The following is a description of a gene set: Mouse Gene Set: CUI_CDC2_IL15_RESPONSE_DN from publication Cui A, Huang T, Li S, Ma A, Pérez JL, Sander C, Keskin DB, Wu CJ, Fraenkel E, Hacohen N (PMID 38057668) Cytokines mediate cell-cell communication in the immune system and represent important therapeutic targets. A myriad of studies have highlighted their central role in immune function, yet we lack a global view of the cellular responses of each immune cell type to each cytokine. To address this gap, the authors created the Immune Dictionary, a compendium of single-cell transcriptomic profiles of more than 17 immune cell types in response to each of 86 cytokines (>1,400 cytokine-cell type combinations) in mouse lymph nodes in vivo. A cytokine-centric view of the dictionary revealed that most cytokines induce highly cell-type-specific responses. For example, the inflammatory cytokine interleukin-1β induces distinct gene programmes in almost every cell type. A cell-type-centric view of the dictionary identified more than 66 cytokine-driven cellular polarization states across immune cell types, including previously uncharacterized states such as an interleukin-18-induced polyfunctional natural killer cell state. Genes negatively differentially expressed in cell type: cDC2 (conventional dendritic cell type 2) upon treatment with cytokine: IL-15 in mouse lymph nodes in vivo. species: Mus musculus, and this is the list of marker genes: Cd79b, Slc38a1, Ssh2, Zfp36l2, Eif4ebp2, Dock11, Plekhm3, Eif3f, Stk10, Trmt112, Eif3e (eukaryotic translation initiation factor 3, subunit E), Ucp2, Klhl24 (NCBI Gene Id 98030), Smc6 (NCBI Gene Id 67241), Shtn1, Apbb1ip, Asap1, Mcemp1, Zfp36l1, Npm1, Rack1, Eif4b, Ccdc88a, Eif4a2, Sptssa, Glud1, Traf3ip3, Ypel3 (yippee like 3), Hps3, Trim7, Ctdsp2, Cep250, Brd3, Btg2, Cbl, Zeb2, Ssbp3 (NCBI Gene Id 72475), Ifngr1, Hnrnpa1, Mxd4, Klf2, Hpgd, Kdm7a, Fmnl1, Pip4k2a, Gdi2, Cdkn1b, Rnf150, Pdlim2, Hes6 (NCBI Gene Id 98321), Ncf2, Ldb1, Nr4a1, Parp1, Skint3, Septin6, Slc12a6, Tubb5, Celf2, Mbnl1, Tsc22d4, Alox5ap (arachidonate 5-lipoxygenase activating protein), Cd300c2, Fos, Prcp, Tbl1xr1 (NCBI Gene Id 99912), Slc66a2, Paip2, Gm2a, Irag2, Mapre2, Ptpn18, Trappc5, Erp29, Emb, Nfam1, Ccl6, Susd3, Kxd1, Bmyc, Ivns1abp, Flt3, Lztfl1, Selenoh, Il16, Borcs6, Elovl5, Naca, Stk17b (serine/threonine kinase 17b (apoptosis-inducing)), H1f2, Abca9, Mknk2, Bnip3l, Tacc1, Rnf130, Cox7a2l, Tent5a, Pabpc1, Higd2a, Tsc22d3, Pold4, Arhgap45, Man2b1, Phf14, Maz, Fosb, Smim5, Dipk1a, Rsrp1, Ighm, Dpy19l1, Prdx6, Fam168a, Lbh, Lamtor4, Mdp1, Sirpa, Clec4a3, Ier2, Bckdha, Marveld1, Akna, Raph1, Mapk3, Ehd4 (NCBI Gene Id 99247), Tep1, Mical1, Aph1c, Gpx1, Tsc22d1, Mycl, Tut4, Klf4, Prkar2a, Slc43a2, Plekhg3, Txnip, Emsy, Slc25a36, Tbc1d9, Atp5mc2, Calhm2, Tob2, Neat1, Otulinl, St8sia6, Bri3, Polr2e, Fes, Niban1, Gpr34, B4galnt1 (NCBI Gene Id 71257), Mapk14, Rgs10, Ccdc88c, Kctd12, Hltf, Clec2i, Tifab, Uba52, Lyl1, Il6ra, Fam107b, Lpin1, Zfp710, Tmem64, Inpp5d, Tnfaip8, Ppfia4, Vsir, Nap1l1, Prkacb, B4galt6, Casp2, Sash3, Fbrsl1, Dusp1, H2-DMa, Acss1, Clec4a2, BC028528, Eef1a1, Ramp1, Amz1, Spib, Nav1, Arpc5l, Cbx3, Rgs2, Foxp1, Ccr2, Eid1, Ttc3, Ctsh, Lasp1, Tmem234, Tmcc1, Sla, St8sia4, Tnrc6b, Egr1, Arhgef6, Pid1, Macf1, Eef2, Maf1, Hmgb2, Clec4b1, Pdcd4, Dapk1, Mast3, Pycard, Rbfa, Nsa2, Mef2c, Nr4a2, Zfp36, Slc46a3, Spn, Rnd3, Gpi1, Dna2, Cx3cr1, Arhgap9, Sox4, Myo1f, Gusb, Add3, Gpsm3 (G-protein signalling modulator 3 (AGS3-like, C. elegans)), Ogt, Lmo4, Rmnd5a, Igsf6, Ffar4, Il6st (NCBI Gene Id 71317), Stk38, Ncoa3 (nuclear receptor coactivator 3), Dnajb14, Stard9, Bri3bp, Arhgap25, Adcy7, Limd2, Akap13, Rgs18, Tm6sf1, Clint1, Ccpg1, Ptpn22